The following is a description of a gene set: studied in species Mus musculus Genes predicted to be targets of miRBase v22 microRNA mmu_miR_7670_3p in miRDB v6.0 with MirTarget v4 prediction scores > 80 (high confidence targets). Mouse Gene Set: MIR_7670_3P from publication Chen Y, Wang X (PMID 31504780), and this is the list of marker genes: Pgpep1l, Rere (NCBI Gene Id 68703), Ssh2, Mbnl1, Esr1, Pdcd10, Rhobtb3, Glis3, Wnk1, Rims2, Atp2b1, Zcchc24, Spop, Synj2, Sash1, Nova1, Lgals3, Ssr3, Trp53inp1, Evc2, Vgll3, Tmem164, Ankrd13a, Slc49a4, Rreb1, Dnajc14, Dennd1b, Pcgf3, Dpy19l4, Tppp, Lhfpl6, Ap2a2, Hycc1, P2rx7, Ap1s2, Slc39a9, Sf3b1, Tsr1, Plxna2, Arx, Lnpep, Slc38a9, Tanc2, Napg (NCBI Gene Id 71953), Has2, Npas3, Dlg1, Chn2, Rnf122 (NCBI Gene Id 68867), Sirt1, Ago1 (argonaute RISC catalytic subunit 1), Rtkn2, Zfp36l1, Ucp1 (NCBI Gene Id 22227), Tent5a, Eif5, Gpatch11, Dcun1d3, Zfhx3, Mmp13, Coro1c, Brd3, Abcb10, Hoxc8, Rell1, Frs2 (fibroblast growth factor receptor substrate 2), Arap2, Elavl3, Sox11, Spryd7, Ebf2, Mapre2, Pex5l, Lin7a (NCBI Gene Id 93744), Zranb3, Ccdc117, Ppargc1a, Grm1, Trim12c, Nrbf2, Eef1e1, Rnf138, Aoah, Fbn2, Abraxas2, Acer2, Plekhm3, Snx13, Mmgt1, Prrx1, Zfp146, Insc, Zfhx4, Crat, Nanos1, Cdh4, Ezr, Angpt1, H2-M2, Nuak1, Xrn1, Gcnt2, Micu3, A630023A22Rik, Ism1, Gxylt2, Mmab, Inpp4a, Mlxip, Birc6, Crtac1, Nin (NCBI Gene Id 73198), 2310002L09Rik, Hyal4, Lhfpl4, Tox3, Clmp (CXADR-like membrane protein), Uba6, Alcam, Mrps33, Tnfaip8, Ppm1k, Arid3b, Zfp11, Poli, Pde12 (NCBI Gene Id 211948), Mmrn1, Hnrnpa2b1, Ccdc120, Dpp10, Ssrp1, Plcb1, Ephb6, Spred1, Rab22a, Lamp1, Ankfy1, Dync2i1, Onecut2, Foxc1, Tcf12, Iigp1, Alpl, Elf2, Szrd1, Gpm6a, Efnb3, Tmc2, Dhh (NCBI Gene Id 97964), Jarid2, Ski, Zbtb7c, Trim36, Sos1, Rhot1, Ociad2, G2e3, Epdr1 (ependymin related 1), Ncoa7, Pum2, Lrp2, Camk1, Bcas1, Nbea, Gcnt1, Arl8b, Khdrbs1, Epha7, Dmtf1, Ogdh, Kmt5a, Naa15, Tnrc6b, Itpr1, Slc39a11, Cd2ap, Amot, Slc16a6, Pde1c, Nrarp, Gba1, Ttyh1, Tgfbr2, Smim13, St7, Hcn1, Ypel2, Dppa2, Wdr46 (NCBI Gene Id 98062), Dnaaf9, Myo10, Nr3c1, Pts, Pfkfb2, Nr3c2 (nuclear receptor subfamily 3, group C, member 2), Siae, Ap3m1, Lsm5, Pdp1, Farp1, Pcdh12, Tgfbrap1, Zfp629, Igf2r, Mgat3, Rnf170, Mapk4, Nbr1, Fry, Sgip1, Vax2, Rbm41, Tmem263, Smc2, Spta1, Dpf1, Ptprd (NCBI Gene Id 71786), Apol11b, Rps6ka5, Dyrk1a, Adamts5, Rragc, Acsl4, Epha5, Ap1s3, Dnm2, Shc1, Wee1, Chp1, Dvl3, Zfp423, Dtwd1, Hapln1, Rictor, Pid1, Gpbp1l1, Zbed6, Nkx6-3, Ccnt2, Nrg3, Mfsd6, Hook3, Atf6, Fhip1b, Fras1, Arhgap11a, Stk17b, Tomm70a, Samd5, Grk4, Nfatc3, Crkl, Cyp2j12, Pabpc6, Cpne8, Hapstr1, Ntrk2, Larp4b, Zfp521, Zfp282, Rgs12 (regulator of G-protein signaling 12), Epha4, Sec24d, Mcoln1, Tet1, Fam149a, Lypd6b, Ccdc68, Lrrc8d, Ranbp6, Slc43a1, Dnajc13, Esrrg, Fbxw7, Pusl1, Creb5, Slc16a4, Efemp2, Lrrn4cl, Tfap2a, Fnip1, Cox5a (NCBI Gene Id 12858), Atf2, Creb1, Cd74, Dera